The following is a description of a gene set: Low self-esteem Human Gene Set: HP_LOW_SELF_ESTEEM Persistent, excessively negative, and critical thoughts of one's personal abilities, attributes, or any feature related to the self and self-attitude. The affected individual believes they are a lesser being compared to others in their social peer group. species: Homo sapiens, and this is the list of marker genes: MSX1, FMO3, CACNA1H, JRK, NECTIN1, GABRB3 (NCBI Gene Id 2562), IRF6, SLC2A1, GABRG2, GABRA1, TP63